Given this list of marker genes ADRA2A, TGM2, P2RY1, CHRNB2, SLC18A2, CHRNA4, VIP, ADRA2C, PARK7, GNAT1, CXCL12, SYT1, SLC22A3, GRK2 (G protein-coupled receptor kinase 2), SYT11, HTR1A, ADRA2B, CHRNA6, LILRB1, ADORA3, ADORA2A, HTR1B, SLC29A4, SLC18A1, PINK1, FCER1G, HTR2A, FGF20 (fibroblast growth factor 20), SLC18A3, SLC29A3, NOS1, KCNB1, DRD4, RAB3B, CARTPT, CHGA, SYK, PICK1, COMT, GABBR1, GRM2, GPM6B, SLC18B1, SLC6A4, KCNA2, DTNBP1, GDNF, P2RX1, OPRK1, SLC6A3, OXT, DRD3, MAPK15, GHSR (growth hormone secretagogue receptor), DRD1, MECP2, SLC6A2, CHRM5, SLC22A2, ACTB, ABAT, STX1A, FFAR3, SYT4, NPY2R, SNCA, CRH, KPNA4, SNCG, SLC22A1, ITGB3 (NCBI Gene Id 3690), PRKN, SDHD, TOR1A, DRD2, here is a description of the gene set: The directed movement of monoamines, organic compounds that contain one amino group that is connected to an aromatic ring by an ethylene group (-CH2-CH2-), into, out of or within a cell, or between cells, by means of some agent such as a transporter or pore. studied in species Homo sapiens Human Gene Set: GOBP_MONOAMINE_TRANSPORT